The following is a description of a gene set: The expansion of a T cell population following activation by an antigenic stimulus. studied in species Mus musculus Mouse Gene Set: GOBP_ACTIVATED_T_CELL_PROLIFERATION, and this is the list of marker genes: Scrib, Arg1, Il2ra, Itgad (integrin, alpha D), Icosl, Casp3, Il23a, Itgax, Itgam, Ephb6, Satb1, Itgal, Lrrc32, Crtam, Stat5a, Ager, Ppp3ca, Igf1, Itgb2, Lilrb4b, Il12rb1, Il12b, Fadd, Slamf1, Prnp, Igfbp2, Rps3, Il4, Laptm5, Cd274, Btn2a2, Gpam, Cd24a, Il18, Cd86, Tnfsf9, Hmgb1, Il2, Stat5b, Pycard (PYD and CARD domain containing), Tnfsf4, Prkar1a, Igf2, Jak3, Pdcd1lg2, Fyn, Abl1, Epo, Lilrb4a, Ripk3, Ido1, Rc3h1